Given this list of marker genes Apobec3, Apobec2, Apobec4, here is a description of the gene set: This event has been computationally inferred from an event that has been demonstrated in another species.<p>The inference is based on the homology mapping from PANTHER. Briefly, reactions for which all involved PhysicalEntities (in input, output and catalyst) have a mapped orthologue/paralogue (for complexes at least 75% of components must have a mapping) are inferred to the other species. Reactome Pathway: mRNA Editing studied in species Mus musculus part of: Metabolism of RNA electronically inferred by orthology from the curated human pathway